The following is a description of a gene set: studied in species Homo sapiens A histone acetyltransferase complex that catalyzes the acetylation of a histone H4 lysine residues at several positions. In human, it contains the catalytic subunit MOF, NSL1/KIAA1267, NSL2/KANSL2, NSL3/KANSL3, MCRS1, PHF20, OGT1, WDR5 and HCF1. Human Gene Set: GOCC_NSL_COMPLEX, and this is the list of marker genes: PHF20, KAT8, KANSL1L, KANSL1, KANSL2 (KAT8 regulatory NSL complex subunit 2), WDR5, MCRS1, PHF20L1, KANSL3, OGT, HCFC1